The following is a description of a gene set: We have assessed the possibility to build a prognosis predictor (PP), based on non-neoplastic mucosa microarray gene expression measures, for stage II colon cancer patients. Non-neoplastic colonic mucosa mRNA samples from 24 patients (10 with a metachronous metastasis, 14 with no recurrence) were profiled using the Affymetrix HGU133A GeneChip. Patients were repeatedly and randomly divided into 1000 training sets (TSs) of size 16 and validation sets (VS) of size 8. For each TS/VS split, a 70-gene PP, identified on the TS by selecting the 70 most differentially expressed genes and applying diagonal linear discriminant analysis, was used to predict the prognoses of VS patients. Mean prognosis prediction performances of the 70-gene PP were 81.8% for accuracy, 73.0% for sensitivity and 87.1% for specificity. Informative genes suggested branching signal-transduction pathways with possible extensive networks between individual pathways. They also included genes coding for proteins involved in immune surveillance. In conclusion, our study suggests that one can build an accurate PP for stage II colon cancer patients, based on non-neoplastic mucosa microarray gene expression measures. studied in species Homo sapiens Up-regulated genes from the 70-gene prognosis predictor for stage 2 colon cancer, based on non-neoplastic mucosa gene expression profiles. Human Gene Set: BARRIER_COLON_CANCER_RECURRENCE_UP from publication Barrier A, Roser F, Boëlle PY, Franc B, Tse C, Brault D, Lacaine F, Houry S, Callard P, Penna C, Debuire B, Flahault A, Dudoit S, Lemoine A (PMID 17043639), and this is the list of marker genes: FOXO1, SNU13, XPNPEP1, SRP72, HGD, CNPY2, POLD3, SEC62, WDHD1, DNAJC12, SLC18A1, SCEL, PSMC2, TRIM2, NME7 (NCBI Gene Id 29922), COPS8, ITM2A, PWP1, RPN2, EXT2, THOC2, UGGT1, YIPF6, YIPF1, AHI1, ERGIC2, ANXA2, TENT5A, GPR89B, SULT1C2, SLCO4A1, PDHB, CFH, CIAO1, TIMM17A, ANG, GPR171, SAR1A, KDELR3 (KDEL endoplasmic reticulum protein retention receptor 3), ARL1, NDEL1, METTL9